Given this list of marker genes B3GLCT, DYRK1A, HMGA2, ORC6, PLAG1, CDC6, CDT1, FIG4, TBCE, SMAD4, ORC1, EIF2S3, ORC4, SMPD4, PIK3R1, here is a description of the gene set: Birth length less than 3rd percentile studied in species Homo sapiens Human Gene Set: HP_BIRTH_LENGTH_LESS_THAN_3RD_PERCENTILE